The following is a description of a gene set: from publication Chen Y, Wang X (PMID 31504780) Human Gene Set: MIR3667_3P Genes predicted to be targets of miRBase v22 microRNA hsa-miR-3667-3p in miRDB v6.0 with MirTarget v4 prediction scores > 80 (high confidence targets). species: Homo sapiens, and this is the list of marker genes: WFDC13, ST6GALNAC3, ZNF516, ENSA, CCBE1, MUCL3 (mucin like 3), AHCYL2, CCDC182, TOR1A, CDCA3, CXCL10, DYNC1LI2, AMER1, RND1, PLXNA2 (plexin A2), ZFP91, DNAJC25-GNG10, PALLD, CDC14A, PITPNB, VANGL1, KCNRG, DCDC2, FAM53C, LRRC49 (leucine rich repeat containing 49), CEP41, APH1A, STC2, ATP1A2, ATXN7, HERPUD1, CEP350, BCL2L13, GNG10, PAPPA, NAV1, PFKFB2, SNX29, YTHDF3, ENOSF1, ARF6, ORMDL1, ADGRF5, NMNAT2, MTMR3, ABR, DCAF8, CCDC62, KDR, NFE2L1, SHISAL1, KLK7, HCFC2, ETS1, NKD1, MBD5, SSTR3, C5orf22, HRAS, MARCHF3, GPR26, AFDN (NCBI Gene Id 92217), TNRC6B, CT62, IGFBP2, HAS2, PPM1N, PARP1, STX2, ALKBH5, N4BP2, UNKL, JHY, CHST11, ARHGEF26, MLLT6 (MLLT6, PHD finger containing), ENTREP1 (endosomal transmembrane epsin interactor 1), CDAN1, COMMD10, TGFBR1, CDC42, KSR2, UPRT, RAB11FIP4, PTCH1, SEPTIN10, TET3, CDK14, DTHD1, BICRAL, GPR68, FGF5, TSC1 (TSC complex subunit 1), COLEC10, CEACAM1, POP1, CA12, SLC43A2, LEP, CAAP1, POU2F1, ZNF81, ZFP42, ATXN1L, HIPK2, LGALSL, IBSP, KCNAB2, CMKLR2, PRKD3, NDUFB4, SIRPA, MRAS, TAB2, OAT, CASTOR3P, MGAM2, CHODL, MOSPD1, NECAP2, KIAA0513, SELENOW, BICD2, MC2R, STRN, RPUSD4, CHD1, OXR1, PLCXD3, LPP, LHFPL6, UBE2I, LSAMP, NEGR1 (neuronal growth regulator 1), TBX18, SPEG, NCOR2, GNG11, PPP1R1C, ZKSCAN7, TBC1D16, MLEC, H6PD, SDK1, PRDM4, BRPF3, LRIF1, AGAP1, CBL, SHC3, C3orf33, CLMP